Given this list of marker genes Fbxl13, Fbxw7, Fbxo24, Fbxl7, Cul1, Fbxw8, Fbxo3, Fbxl4, Daw1, Fbxo25, Fbxl20, Spsb3, Skp1, Fbxo27, Spsb2, Fbxo7, Fbxl3, Fbxl2, Trim21, Fbxo44, Rbx1, Fbxw5, Fbxo31, Fbxl15, Fbxl9, Fbxo17, Fbxo4, Dmac2, Nccrp1, Amn1, Fbxw4, Skp2, Fbxo32, Cul5, Fbh1, Fbxo39, Arih1, Fbxl18, Cacybp, Tmem183a, Fbxl17, Fbxl19, Spsb4, Usp47, Fbxl5, Fbxo9, Fbxl14, Fbxo45, Cks2, Fbxl22, Fbxw11, Fbxo42, Fbxo15, Fbxl16, Cul2, Rbx1-ps, Spsb1, Fbxo48, Btrc, Cks1brt (NCBI Gene Id 633546), Cks1b, Fbxl21, Fbxo6, Ccnf, Fbxo2, Fbxl6, Siah1a, Pnkp, here is a description of the gene set: Mouse Gene Set: GOCC_SCF_UBIQUITIN_LIGASE_COMPLEX studied in species Mus musculus A ubiquitin ligase complex in which a cullin from the Cul1 subfamily and a RING domain protein form the catalytic core; substrate specificity is conferred by a Skp1 adaptor and an F-box protein. SCF complexes are involved in targeting proteins for degradation by the proteasome. The best characterized complexes are those from yeast and mammals (with core subunits named Cdc53/Cul1, Rbx1/Hrt1/Roc1).